The following is a description of a gene set: Any process that increases the rate, frequency, or extent of inclusion body assembly. Inclusion body assembly is the aggregation, arrangement and bonding together of a set of components to form an inclusion body. Human Gene Set: GOBP_POSITIVE_REGULATION_OF_INCLUSION_BODY_ASSEMBLY species: Homo sapiens, and this is the list of marker genes: PSMC6, APOE, PSMC5, CLU, HSF1